Given this list of marker genes CLEC2D, SEC61G, IGKV1-12, TEAD1, SUZ12, RAF1, DCTN1, TIRAP, H2AZ2, CCND1, ANAPC10, PPP2R5C, RASGRP2, FCGR2B, SIGLEC5, ANAPC7, FBXW9, KLHL25, HERC6, GLMN, RAB7A, KIF2C, PSMD11, KLC3, H2BC3, RNF130, TRIM11, IGHD (immunoglobulin heavy constant delta), PRR5, IGKV2-28, CLTC, FGG, FBXO44, SH3KBP1, BLMH, IGLC1, SFTPD, MIR140, RPS27A, UBE2J1, ANAPC13, ORAI2, DTX3L, FBXO11, BLNK, RPN2, KIR2DS2, RNF182, PIK3AP1, TRIM4 (NCBI Gene Id 89122), IGLC6, KIF4B, HIF1A, ELOC, FOSB, PIANP, MYCN, FCGR3A, REL, SIPA1, INPP5D, HLA-DPA1, RNF34, CD300A, RBCK1, SH2D1A, DYNLL1, FBXO15, MTOR, SIAH1, ZBTB16 (zinc finger and BTB domain containing 16), HLA-DQA1, S100A8, CD8B, CUL5, NPEPPS, IGKV1-16, PSMD14, PSMA3, PSMC6, FBXO27, HLA-DRB1, ANAPC1, COL2A1, UBE2M, IGKV1-5, IGLV4-69, LRRC41, RNF114, RNF111, FCGR1A, FBXO21, B2M, VAMP3, NFKBIB, PSMD12, HLA-DQA2, TREML2, RBBP7, IGHV1-46, JAK1, PSME1, UFL1, IGKV2D-40, MIR142, AREL1, PSMB3, RAP1B, IGKV5-2, CTSA, CTSC, IGLV6-57, IGHV3-33, SEC24A, UBA1, TAPBP, MAP3K7, LILRB4, DET1, CD200, NRAS, KLRF1, IGLV2-33, PPP3CA, SOCS1 (suppressor of cytokine signaling 1), UBA3, PRKAA2, TUBA1B, NFKB1, HA, ATG7, TUBB8B, PRKAB1, PPP2R5E (protein phosphatase 2 regulatory subunit B'epsilon), LAIR1, SIGLEC7, KCTD6, PSMD7, HLA-F, NFKBIE, ASB12, UBE2D1, TUBA1C, HACE1, IGKV1D-12, UBE2D4, CD209, LILRB2 (NCBI Gene Id 10288), MIB2, SOS1, PSMB8 (NCBI Gene Id 5696), HLA-DRA (major histocompatibility complex, class II, DR alpha), 8, PIK3R3, PPP2CB, PLCG2, CD160, CAPZA2, ITPR2, H2BC21, IGKV4-1, CD8A, PAG1, KIF20A, VHL, LNX1, MGRN1, UBE2J2, TUBA8, H2BC1, ASB16 (NCBI Gene Id 92591), SEC61A2 (SEC61 translocon subunit alpha 2), DNM2, PSMA1, FKBP1A, PIK3CG, MIR200B, TNFRSF14, CXADR, PIK3C3, IKBKG, BRD4, TEAD3, IGLV3-12, MIR340, MKRN1, MAP3K14, H2AC7 (NCBI Gene Id 3013), KBTBD7, PTEN, GRAP2 (GRB2 related adaptor protein 2), CD81, IGKC, RNF19A, HERC1, IGKV1-33 (immunoglobulin kappa variable 1-33), LILRA2, STX4, PRKCB (NCBI Gene Id 5579), H2AB1, KLHL41 (kelch like family member 41), KBTBD8, PSMA6, LCP2, MOV10, COL1A2, GSK3B, IGHV1-2, IGHV3-30, CCNF, CTSO, KIF11, IGKV1-39, ACTR10, CDC42, CARD11, FBXO2, IGLV7-46, AHCYL1, MIR34C, IGHV4-34, IGKV3-15, LILRA3, IGLC7 (immunoglobulin lambda constant 7), IGHV4-59, NCF2, S100A1, IGKV3-20, ICAM3 (NCBI Gene Id 3385), CD79B, FBXL20, IGHV2-5, UBR4, EZH2, IGKV1D-39, KLHL22, EP300, PSMB7, CD226, VAMP8, HLA-DMA, KLHL5, IGHV3-48, CD79A, PRKAB2 (protein kinase AMP-activated non-catalytic subunit beta 2), UBE2H, NEK2, FBXO30, CLEC4G, BTN2A1, TRAV8-4, CENPE, COL3A1, H2BC9, IGKV1-17, CUL2, RNF41, CD86, SYK, PSMC2, THEM4, RNF4, RICTOR, HLA-DRB3, CDC27, BCAP31, AP1S2, CSNK2A2, TUBA3C, PLCG1, PRKACB, COL17A1, HLA-B, CBLL2 (Cbl proto-oncogene like 2), TUBA3D, PSMD2, CYBA, KIF5B, PILRB, UBE2O, HLA-DQB1, IGLV3-21, STUB1, EPAS1, UBE2D3, CAPZA3, AP2M1, UBE2G2, PIK3R1 (NCBI Gene Id 5295), SOCS3, TLR2, PSMD6, ERAP2, KIR2DL4, KLHL13, CBLB, IGLV, HLA-DRB4, PIK3CD (NCBI Gene Id 5293), H2BC11, KLHL42, WAS, IGHV4-39, SH3GL2, DZIP3, LILRA6, TCF7, FBXO4, PJA1, TRIM50, IGLV1-40 (immunoglobulin lambda variable 1-40), LCK, ICAM2, NCK1, RAPGEF3, ITGB5, CDC23, FYN, FBXL15, UBE2B, ASB13, SEC61B, PPP2R1A, UBR1, HECTD3, CD40, TRIM41, PSMD3, porB, PDPK1, DERL2, AKT3, MICA, RBBP6, KIF3B, TRIM63, IFITM1, SIGLEC10, ITGB1, FBXO22, ITK, MIR93, FBXW7 (NCBI Gene Id 55294), UBE3D, ASB10, UL83, KIR3DL2, HMGB1, PAK2, MEX3C, UNKL, ASB6, TUBB8, LGMN, ADRM1, KMT2C, ITGAL, PTPN6, FBXW5, THOP1, NFATC3, CD1B, ZNRF2, KIF18A, KCTD7, IGLV1-51, PIK3CB, PSMC3, UBE3B, IGLV2-18, NCR3, B3GNT3, COLEC12, CTSF, CD207, RAP1GAP, BTN2A2 (butyrophilin subfamily 2 member A2), AGO1, SIGLEC8, IGLV1-47, CD99, ANAPC5, TPP2, CSK, ITGB7, RIPK2, AGO4, TRIM39, CD3E, ERLEC1, TCF7L2, FBXL16, CD1A, KLHL11, RNF144B, CD22, CLTA (NCBI Gene Id 63271), UBE2V2, CHUK, SAR1B, DCTN3, IGHM, SIGLEC1, ITGA4, PVR, AP1G1, MYLIP, IGLC3 (immunoglobulin lambda constant 3 (Kern-Oz+ marker)), IGLV5-45, SEC31A, IGKV2-30, MADCAM1, TUBB4A, KBTBD6, TRIM21, SLAMF7, CD40LG, TUBA3E (NCBI Gene Id 150521), PSMB6, ASB9, UBE2C, FBXO40, SEC22B, TRPC1, NFKBIA, ANAPC11, PIK3R6, RNF7, IGLV3-19, RNF138, LTN1, UBE2K, MAPKAP1, HERC2, CSNK2B, PSMD13, HLA-DRB5, BTN3A2, FBXW11, OS9, H2BC5, HLA-DPB1, ITPR1, AP2B1, TRIM9, LILRA4, CD1C, KIF3A, DYNC1I2, TCF7L1, H2AC20, RBX1, AP1S3, TLR6, KIFAP3, TRIM69, RAET1E, SEC61A1, FZR1, CREBBP, LILRB3, H2BC17, PRKCQ, TUSC3, MIR424, PSMA2, ASB7, TUBB2A (NCBI Gene Id 92919), UBE2N, BTRC, MIR429, UBE2Q2, ERLIN2, FBXL14, JUND, TLR4, MIR200C, LAT, PSMC4, PSMA4, PIK3CA, EVL, KIR2DL1, IGLV3-22, KLHL3, CUL3 (cullin 3), UBB, CD300LG, LNPEP, SEM1, ORAI1, HECW2, PDCD1, RNF115, NFKB2, ASH2L, SMURF1, BLK, H2AX, PRKAG2, UBA52, SH3RF1, IRF1, UBE2Q1, IGLV2-23, AGO3, HLA-H, TRAC, TNRC6C, IGKV3D-20, MYD88, DCTN2, STAT1, TLR1, ITGAV, CLEC2B, H2BC26, KLRC1, MLST8 (MTOR associated protein, LST8 homolog), SEC24D, ERLIN1, NEDD4, IFI30, PPP2R5A, RAPGEF4, NFATC2, VASP, TRAF6 (NCBI Gene Id 7189), H2BC12L, FBXL5, IGHV7-81, DYNC1H1 (NCBI Gene Id 992), MYC, IGLV2-8, CDH1, KLC2, IGLV7-43, IGLV4-60, KIF26A, FBXO6 (NCBI Gene Id 55822), PRKAG1, GAN, KLHL21, PSMA5, BTNL8, CD300LB, PSMD8, TUBA4A, IGLV1-36, CD36, ASB5, AP1S1, HLA-A, CD3D, PIK3R2, IGLV4-3, TRIP12, PSMD1, KIF3C, AKT2, ANAPC2, CD34, AP2A1, RNF126, KIF15, CTSS, FBXO7, RNF19B, CD80, IGHV3-11, HRAS, ASB8, TRAF7, YAP1, FBXW4, OSBPL1A, SPTBN2, H3C15, AGO2, IGKV3-11, HERC4, DNM3, CTSB, ATF3, LONRF1, S100A9, CD33, UBA5, ICOSLG, IGHV, HCST, PSME2, CAPZA1, SNAP23, CD101, IGKV2D-30, KLC1, TNRC6A, UBE2L3, UBE2E2, NFATC1 (NCBI Gene Id 4772), KIF2A, RASGRP3, CTLA4, CD3G, DCTN5, ASB15, H2BC15 (NCBI Gene Id 8341), UBE2E1, MIR34B, YWHAB, ASB17 (NCBI Gene Id 127247), PPP2R5D, MIR34A, UBE2F, ERAP1, DAPP1, AP2A2 (adaptor related protein complex 2 subunit alpha 2), TUBB6, PAK1, PRKACG, PIK3R5, ARF1, NCF1, CD300E, FBXL18, IGLV3-1, RNF6, ULBP3, WWP1, ANAPC4, SIGLEC6, SRC, DCAF1, TUBB1, FBXL22, FOS, FBXO31, KLRK1, RAC1, IGHV3-53, PRKAA1, BTN3A1, AKT1, RNF220, NCR2, H3C1, HSPA5, BTNL2, RNF14, PAK3, CSNK2A1, CRTAM, CD274, LRR1, FBXO32, FBXW8, VCAM1, CTSH (NCBI Gene Id 1512), ASB11, IGLV3-25, BTLA (B and T lymphocyte associated), WWTR1, PPP2CA, CDC16, RPN1, RNF217, KIR3DL1, RNF25, YWHAG, IGLV8-61, TRIM32, CTNNB1, BTN1A1, CD1D, PSMB4, FGB, LAG3, TRAV19, PPP2R1B, CALM1, SPOP, RBBP5, NCR1, ITCH, LILRB5, SPSB1, SEC13, N, PSMB2, PSMB1, IGHV3-13, UBAC1, SIGLEC12, COPS5, UBE3A, ULBP1, PTPRC, IGLV2-11, DYNC1LI2, VCP (NCBI Gene Id 94731), KIF2B, IGKV2D-28, NPDC1, IGHV3-7, CD247, FBXL7, C3, PPIA, HLA-DMB, PPP3CB, HLA-DOA, UBE3C, IGKV2-29, COL1A1, TEAD2 (TEA domain transcription factor 2), IGLV5-37, PSMC5, RNF123, DYNLL2, CD28, HN, LRSAM1, YWHAZ, TAP1, UBE2R2, WSB1, OSCAR, LEF1, KLHL9, IGHV1-69 (immunoglobulin heavy variable 1-69), ATG14, RLIM, PTPN22, H2AC6, RBBP4, TRBV7-9, FBXL8, TRAT1, EED, RACGAP1 (NCBI Gene Id 94651), STAT3, TAB2, CAPZB, BTK (Bruton tyrosine kinase), CD300LF, FBXL3, XDH, DYNC1LI1, NCR3LG1, SELL, PIK3R4, DYNC1I1, PRKN, TRIB3, ZNRF1, ENAH, RAP1A, BTBD1, SIAH2, SKP2, YES1, FBXO9, UBE2D2, KMT2A (lysine methyltransferase 2A), AP1M1, H2BC14, TRAV29DV5, FBXL21P, CD74, FBXW12, WDR5, CTSK, GRB2, KIF23, CD19, KIR2DL2, HECTD1, TRIM37, ZAP70, PSMB9, CUL7, TRAIP, IGLV3-16, UBE2W (NCBI Gene Id 55284, ubiquitin conjugating enzyme E2 W), NCF4, ARIH2, FBXO41, RASGRP1, HECTD2, PRKG1, TRBV12-3 (NCBI Gene Id 28577), ICAM4, PRKAG3, TRBC1, TUBA4B, CUL1, H2BC4, KIR2DS1, TRIM71, H2BC13, RNF5, KEAP1, ASB4, TUBB4B, LY96, ITPR3, M, FBXO17, FBXO10 (NCBI Gene Id 26267), DNM1, IGHV3-9, CALR (NCBI Gene Id 811), DCTN6, AP2S1, KIR2DL3, MIR138-1, IGHV2-70, HLA-E, FBXL13, PPL, IGLV11-55, HLA-DOB, CD300C, PSMC1, PSMB10, CD96, UBE2U, TYROBP (transmembrane immune signaling adaptor TYROBP), SKP1, FGA, CANX, BTBD6 (BTB domain containing 6), AP1B1, SH2D1B, UBE4A, BTNL9, JAML, UBE2E3, CD200R1, IKBKB, RILP, FBXL19, DCTN4, ICOS, KIF5C, PILRA, mip, GLYCAM1, NEDD4L (NEDD4 like E3 ubiquitin protein ligase), UBE2V1, FBXL12, MICB, H2AC18, CTSD, SEL1L, UBA6, CYBB, PSMA7, ASB2, IGKV1D-16, KIF22 (kinesin family member 22), ICAM1, TREML1, CDC20, KRAS, MALT1, DPY30, SEC23A, LILRB1, UBE2L6, H4C1, IGLV3-27, KLHL2, IGLV2-14, SIGLEC9, MRC1 (mannose receptor C-type 1), RAP1GAP2, ASB14, TAP2, PPP2R5B (NCBI Gene Id 5526), LILRA5 (leukocyte immunoglobulin like receptor A5), IGLV10-54, IGKV1D-33, CD4, DDOST, MAP3K8, ITGB2, SLAMF6 (NCBI Gene Id 114836), STT3A, FYB1, H2AC4, HLA-C, BCL10, ACTR1B, MIR148A, SPSB2, JUN, MIR152, KBTBD13, CTSL, PDCD1LG2, SEC24C, cd21, PTPRJ, KLHL20, STIM1, UBA7, TREM2, ICAM5, MAGT1, PPP3R1, TUBA1A, HLA-DQB2, SEC24B, TRIM36, TREM1, SPSB4, PDIA3, OST4, SIGLEC11, H2BC12, BTN3A3, MRC2, ACTR1A, TNRC6B, UBC, MIRLET7A1, UBE2G1, BECN1 (NCBI Gene Id 8678), KLRB1, HERC5, OSTC, UBOX5, LAIR2, H3-3A, PSMB5, IGHV3-23, UBE2A, NFE2L2 (NFE2 like bZIP transcription factor 2), RCHY1, PJA2, CD300LD, H2AJ, LYN, KLC4, TMEM258, ELOB, KLRG1, CDC26, UBE2Z, VAV1, CDC34, HLA-G, CTSE, CDK4, PRKACA, TEAD4, UBE2S, TUBB3, LMO7, NECTIN2, TUBB2B, FCGR1BP, FBXW2, CD14, DAD1, PTPN11, FBXL4, RELA, FBXW10, KIF5A, TUBAL3, IGLV1-44, RNF185, SMURF2, AP1M2, DERL3, ASB1, KIF4A, TREML4, LILRA1, CTSV, HERC3, DERL1, ASB18, H2AC14, IGLC2, RNF213, HUWE1, UBR2, STT3B (NCBI Gene Id 201595), ASB3, KLRD1, here is a description of the gene set: Reactome Pathway: Adaptive Immune System part of: Immune System species: Homo sapiens Adaptive immunity refers to antigen-specific immune response efficiently involved in clearing the pathogens. The adaptive immune system is comprised of B and T lymphocytes that express receptors with remarkable diversity tailored to recognize aspects of particular pathogens or antigens. During infection, dendritic cells (DC) which act as sentinels in the peripheral tissues recognize and pick up the pathogen in the form of antigenic determinants and then process these antigens and present them to T cells. These T cells of appropriate specificity respond to the antigen, and either kill the pathogen directly or secrete cytokines that will stimulate B lymphocyte response. B cells provide humoral immunity by secreting antibodies specific for the pathogen or antigen.